The following is a description of a gene set: Enables the transfer of L-lysine from one side of a membrane to the other. L-lysine is 2,6-diaminohexanoic acid. Mouse Gene Set: GOMF_L_LYSINE_TRANSMEMBRANE_TRANSPORTER_ACTIVITY species: Mus musculus, and this is the list of marker genes: Slc25a15, Slc7a6, Slc7a1, Slc25a29, Slc7a2, Slc7a3, Slc66a1, Slc25a2